Given this list of marker genes ST8SIA3, ST6GALNAC5, ST8SIA4, ST6GALNAC4, B4GALT5, B4GALNT1 (NCBI Gene Id 550623), ST8SIA2, B3GALT4, ST6GALNAC6, ST3GAL3, ST3GAL5, ST6GALNAC3, B4GALT6, ST3GAL1, ST3GAL2, ST8SIA6, C20orf173, here is a description of the gene set: The chemical reactions and pathways resulting in the formation of ceramide oligosaccharides carrying in addition to other sugar residues, one or more sialic acid residues. species: Homo sapiens Human Gene Set: GOBP_GANGLIOSIDE_BIOSYNTHETIC_PROCESS